Given this list of marker genes PNPLA1, GJB6, KIFBP, FOXC2, SLC39A4, HLA-B, FGF10, DCN, MBTPS2, MMP1 (matrix metallopeptidase 1), SPINT2, COL7A1, ALOXE3, PRDM5, ALOX12B, ALDH3A2, TGM1, COL4A4, FGFR2, PERCC1 (proline and glutamate rich with coiled coil 1), KRT3, GJB2, IKZF1, SULT2B1, ELP1, CHST6, FGFR3, NIPAL4, CLTCL1, WT1, TGFBI, TWIST2, PAX6, TP63, ABCA12, ZNF469, CTNS, COL17A1, NTRK1, FERMT1, SDR9C7, COL4A5, CERS3, EPCAM, MPV17, PLCG2, here is a description of the gene set: Corneal erosion species: Homo sapiens Human Gene Set: HP_CORNEAL_EROSION An erosion or abrasion of the cornea's outermost layer of epithelial cells.